Given this list of marker genes Kat7, Dhrs9, Esr1, Osbpl6, Ppp3cb, Phyhipl, Cbfa2t3, Fgf13, Zfp764l1, Arid2, Ptk2, Zfp764, Cdh17, Cracd, Esp34, Rtn1, Vwa8, Zfp747l1, Tbc1d9, Map3k12, Lrp8, Bnc2 (basonuclin zinc finger protein 2), Lancl3, Rbbp6, Scd3, Stx16, Ccni (cyclin I), Dusp6, Mbnl3, Ubr3, Rfx3, Zfp503, Aff4, Adgrv1, Fibin, Nhlh2, Lrrtm3, Siglech, Tmem65, Lypd6 (LY6/PLAUR domain containing 6), Cav1, Tmem202, Magi2, Zfp747, Phf20l1, Slc26a4, Arvcf, Fgf9, Zfp799, St8sia4, Sacm1l, Gmnc, Cyp51, Inpp4b, Cpxm2, Negr1, Tcf7, Plekho1, Eid1, Plxnc1, Clns1a, Cnot6l, Txnip, Fam124a, Eva1a, Dynll1, Acat1, Tspan6, Alg13, Mmp21, Pde7a, Arrdc3, Cfhr2, Tgfb1i1, Vps54, Utrn, Rnf169, Trmt10b, Fzd4, Apobec4, Pde5a, Kcnd2, Onecut2, Crebrf, Phb1 (NCBI Gene Id 18673), Foxd3, Srgap2, Hecw1, Nck1, Spred1, Camk1d, Il7r, 2310039H08Rik, Kif26b, Ppm1j, Iqsec3, 2310009B15Rik, Tmem200c, Creb1, Ankrd29, Lgalsl, Zfp114, Dmc1, Hnrnpu, Prex2, Ano1, Nt5dc1, Pggt1b, Nek1, Stmn1, Rnf139, Fut2, Rpusd2, Spon1, here is a description of the gene set: studied in species Mus musculus from publication Chen Y, Wang X (PMID 31504780) Genes predicted to be targets of miRBase v22 microRNA mmu_miR_1897_5p in miRDB v6.0 with MirTarget v4 prediction scores > 80 (high confidence targets). Mouse Gene Set: MIR_1897_5P